Given this list of marker genes Smyd3, Xk, Selenon, Myorg, Six1, Smo, Kel, Myod1, Ryr1 (NCBI Gene Id 20190), Nfatc2, Myog, Lncpint, Col6a1, Hdac5, Norad, Hdac4, Hdac9, Rcan1, Dmd, Cav2, Ppp3cb, P2rx2, Dcaf8, Wnt10b, Cntnap2, Trim63, Large1, Ski, Stac3, Plec, Fbxo22, Tmem182, Klhl40, Pmp22, Cntnap1, Myf6, Actn3, Gpx1, Spg11, Igf1, Cacna1s, Myf5, Myhas, Acta1, Nfatc3, Bcl2, Mir351, Ppp3ca, Bin3, Lmod3, Hottip (Hoxa distal transcript antisense RNA), Dner, Homer1, Shox2, here is a description of the gene set: The process aimed at the progression of a myotube cell over time, from initial commitment of the cell to a specific fate, to the fully functional differentiated cell. Myotubes are multinucleated cells that are formed when proliferating myoblasts exit the cell cycle, differentiate and fuse. studied in species Mus musculus Mouse Gene Set: GOBP_MYOTUBE_CELL_DEVELOPMENT